The following is a description of a gene set: Any process that activates or increases the frequency, rate or extent of receptor internalization. Mouse Gene Set: GOBP_POSITIVE_REGULATION_OF_RECEPTOR_INTERNALIZATION studied in species Mus musculus, and this is the list of marker genes: Aplnr, Grem1, Syk, Egf, Magi2, Sfrp4, Ptpn5, App, Arrb1, Dtnbp1, Pard3, Wnt3a, Ap2m1, Ahi1, Apln, Drd2, Ntf3 (neurotrophin 3), Angpt1, Arrb2, Hamp2, Cd63, Synj2bp, Dab2, Hamp, Fmr1, Plk2 (NCBI Gene Id 20620), Pick1, Pcsk9, Insr, Apela, Atad1, Tbc1d5, Plcg2, Sele, Vegfa